Given this list of marker genes Il12rb1, Nmi, Idnk, Gbp5, Scfd1, Irgm1, Rbm3, Gbp7, Serpina3f, Irf1, Gbp2, Ifi203, Isg15, Tapbp, Psme2, F2r, Gbp6, Creb3, Ifi206, H2-K1, Rab19, Calhm6, Psma5, Socs1, Txn1, H2-T22, Eif2ak2, Daxx, Tapbpl, Itgb7, Plscr3, Dtx3l, Psma2, Rtp4, Dbnl, Tmbim6, Tgtp1, Trim30a, Irf9, Zup1, Ly6a, Ifi35, Hspa5, Parp14, Slfn1, Ifit1 (NCBI Gene Id 15957), Igtp (NCBI Gene Id 16145), Serpina3g, Tap2, Ssbp2, Nlrc5, Calr, Bst2, Psmb10, Nampt, Bbip1, Herc6, Ndufaf8, Ctss, Isg20, Cd82 (CD82 antigen), Sp110, Trim12c, Psmb9, Nub1, Stat1, Phyh (phytanoyl-CoA hydroxylase), H2-Q4, Gbp9, Ifi27l2a, Iigp1, Parp3, Pdia3, Wars1, Tle3, H2-T23, Ifi47, Psmb8, Rnf126, Oas3, Gbp4, Ly6e, Ifit3, Zbp1, Lgals3bp, Apobec3, Stat2, Ciao2a, Psma7, Ssbp1 (single-stranded DNA binding protein 1), Mndal, Tmsb10, Samhd1, Gbp8, Tap1, B2m, Tcea1, Parp9, Irf8 (NCBI Gene Id 15900), Rnf213, Phf11b, Cxcl10, Cd274, Samd9l, Thap3, Xaf1, Selenow, Irgm2, Ppa1, Plaat3, Pomp, Tgtp2, Ifi213, Irf7, Psme1, here is a description of the gene set: Cytokines mediate cell-cell communication in the immune system and represent important therapeutic targets. A myriad of studies have highlighted their central role in immune function, yet we lack a global view of the cellular responses of each immune cell type to each cytokine. To address this gap, the authors created the Immune Dictionary, a compendium of single-cell transcriptomic profiles of more than 17 immune cell types in response to each of 86 cytokines (>1,400 cytokine-cell type combinations) in mouse lymph nodes in vivo. A cytokine-centric view of the dictionary revealed that most cytokines induce highly cell-type-specific responses. For example, the inflammatory cytokine interleukin-1β induces distinct gene programmes in almost every cell type. A cell-type-centric view of the dictionary identified more than 66 cytokine-driven cellular polarization states across immune cell types, including previously uncharacterized states such as an interleukin-18-induced polyfunctional natural killer cell state. Mouse Gene Set: CUI_T_CELL_GD_IFNG_RESPONSE_UP Genes positively differentially expressed in cell type: γδ T cell upon treatment with cytokine: IFN-γ in mouse lymph nodes in vivo. from publication Cui A, Huang T, Li S, Ma A, Pérez JL, Sander C, Keskin DB, Wu CJ, Fraenkel E, Hacohen N (PMID 38057668) species: Mus musculus